Given this list of marker genes C1D, RYR2 (NCBI Gene Id 6262), IGHM (NCBI Gene Id 3507), ANXA9, IGHA1, ATP4A, EIF3C, CAVIN2, JCHAIN, CLHC1, DLG2, PPBP, SIRPG, SIAH1, HFM1, ANKRD30BL, PRSS33, SLCO5A1, here is a description of the gene set: Human Gene Set: HOEK_NK_CELL_2011_2012_TIV_ADULT_7DY_UP species: Homo sapiens Systems biology is an approach to comprehensively study complex interactions within a biological system. Most published systems vaccinology studies have utilized whole blood or peripheral blood mononuclear cells (PBMC) to monitor the immune response after vaccination. Because human blood is comprised of multiple hematopoietic cell types, the potential for masking responses of under-represented cell populations is increased when analyzing whole blood or PBMC. To investigate the contribution of individual cell types to the immune response after vaccination, we established a rapid and efficient method to purify human T and B cells, natural killer (NK) cells, myeloid dendritic cells (mDC), monocytes, and neutrophils from fresh venous blood. Purified cells were fractionated and processed in a single day. RNA-Seq and quantitative shotgun proteomics were performed to determine expression profiles for each cell type prior to and after inactivated seasonal influenza vaccination. Our results show that transcriptomic and proteomic profiles generated from purified immune cells differ significantly from PBMC. Differential expression analysis for each immune cell type also shows unique transcriptomic and proteomic expression profiles as well as changing biological networks at early time points after vaccination. This cell type-specific information provides a more comprehensive approach to monitor vaccine responses. Genes up-regulated in natural killer cell 7d vs 0d in adults after exposure to 2011-2012 trivalent inactivated vaccine (A/California/7/09 (H1N1), A/Perth /16/2009 (H3N2), B/Brisbane/60/2008), time point 7D. Comment: Up-regulated DE RNA transcripts (up >= 1.5x) shared between both TIV-vaccinated donors from publication Hoek KL, Samir P, Howard LM, Niu X, Prasad N, Galassie A, Liu Q, Allos TM, Floyd KA, Guo Y, Shyr Y, Levy SE, Joyce S, Edwards KM, Link AJ (PMID 25706537)